Given this list of marker genes TSEN34, RNASE8, RNASE4, RNASE2, TSEN2, RNASE1, RIDA, RNASET2, here is a description of the gene set: Catalysis of the hydrolysis of ester linkages within ribonucleic acids by creating internal breaks to yield 3'-phosphomonoesters. studied in species Homo sapiens Human Gene Set: GOMF_RNA_ENDONUCLEASE_ACTIVITY_PRODUCING_3_PHOSPHOMONOESTERS